The following is a description of a gene set: Human Gene Set: GOMF_G_PROTEIN_COUPLED_ACETYLCHOLINE_RECEPTOR_ACTIVITY species: Homo sapiens Combining with acetylcholine and transmitting the signal across the membrane by activating an associated G-protein; promotes the exchange of GDP for GTP on the alpha subunit of a heterotrimeric G-protein complex., and this is the list of marker genes: CHRM3, CHRM5 (cholinergic receptor muscarinic 5), CHRM4, CHRM2, CHRM1